Given this list of marker genes Itga4, Slamf1 (signaling lymphocytic activation molecule family member 1), Cd47, Abl1, Mospd2, Stk39, Spn, Jam3, Calr, C3ar1, Cxcl13, Selenok, Pycard, Nedd9, Tmem102, Mapk3, Cxcl17, P2ry12, Coro1a, Ptk2b, Ccr7, Cx3cr1, Ccl1, Ccl2, Ccl21b, Csf1r, Jam2, Fpr2, Ano6 (anoctamin 6), Ccl7, Adam8, Ccl21e, Creb3, Trpv4, C5ar1, Wnt5a, Akirin1, Lgals9, Cd99l2, Aif1, Adam17, Serpine1, P2rx4, Tnfsf18, Tnfrsf14, Ccl21a, Defb25, Ptprj, Gas6, Madcam1, Pdgfd, Mdk, Hmgb1, P4hb, App, Tgfb1, Fpr-rs4, Fpr-rs3, Abl2, Il12a, S100a14, Ccr2, Fpr-rs6, Rarres2, BC037156, Ptk2, Ccr1l1, Trem1, Cxcl12, Oxsr1, Ccl21f, Ascl2, Xcl1, Lgals3, Ager, Ccl3, Med23, Wnk1, Itgb3, C1qbp, Mstn, Cmklr1, Tnfsf4, Csf1, Rtn4, Cx3cl1, Pla2g7, Cxcl14, Spi1, Fpr-rs7, Ccl21d, Adam10, Trem2, Il34, Mapk1, Tnfsf14, Ccl20, Cxcl10, Lgmn, Ccl5, Mmp14, Thbs1, Ccr1, Il4, Dock8, Ccr6, Rhoa, Fadd, here is a description of the gene set: Mouse Gene Set: GOBP_POSITIVE_REGULATION_OF_MONONUCLEAR_CELL_MIGRATION species: Mus musculus Any process that increases the rate, frequency or extent of mononuclear cell migration. Mononuclear cell migration is the movement of a mononuclear cell within or between different tissues and organs of the body.